Given this list of marker genes CCDC102B, BTNL8 (butyrophilin like 8), KMT5A, PGAP6, CDH8, CD320, SEZ6L2, SDHA, TUBGCP5, TPRA1, WWC2, SCN2B, TMEM259 (NCBI Gene Id 91304), BCAM, EHBP1L1, ATG4B, SMG1, MAP4K2, NAA15, ATP13A2, RING1, EGFL7, CAPG, KMT2D, TRPM4, SPTB, IKZF5, ADAM15, KDM2A, MAD1L1, ALKBH4, SGK1, GNA13, FBXO40, PHC2, TOLLIP, PYCR3, ZNF250, GRAPL-AS1, BCKDK (NCBI Gene Id 94996), NFKB2, SNX29P2, SLC52A2, ZNF688, DNAJB5, CAPN15, SMTN, ZWILCH, ZNF512B, HIC1, NAA35, FGF20, GCM2, LMAN1, GJC2, DBF4, PKN1, RAPGEF1, ZFP37, MBD3, IFT81, MSMB, LRRC23, SNCB, PITPNM1, PKP1, SH3GLB2, DMBT1, NECTIN3, TACR3, CDH9, NSMF, BAG6, NCOA3, COMT, ZNF652, EPHA1, POU3F4, ANKHD1, PSMC3IP, USP7, ST7L, THOP1, USF2, TEX12, GFUS, H2BC7, RER1, TUBB3, CAD, VEZF1, UNKL, DNAJC24, RAB23, PRRC1, PLK3, PDZRN3, FMNL1, DOK3, CDK16, RFNG, NACC2, GLP2R, ZKSCAN4 (zinc finger with KRAB and SCAN domains 4), SPRR1B (small proline rich protein 1B), SCAND1, ZNF574, FAM149B1, LHX2, BICDL1, APBB3, WEE1, ILKAP, CENPB, ASIP, ZNF148, ARPC2, RABL3, FRAT1, POLD1, GNB2, IER2, PTOV1, EMX1, CDKN2AIP, LMF2, HOXD11, ATP11A, PPP1R3C, GCC1, CDK7, TPM4, CRY2, ZBED1, RELB, KIR2DS1, DESI1, CIZ1, PLEC, UPF1, MISP (NCBI Gene Id 126353), ZBTB25, FRS3, CYP3A4, B4GALT2, CDX1, ZNF74, SRPRA, AURKAIP1, VPS4A, A4GNT, DNAAF2, OLIG2, FAAH (fatty acid amide hydrolase), GPC1, PRKCZ-AS1 (PRKCZ antisense RNA 1), RPS6KB2, TRPC4AP, MVD, FGF6, SNAI2, FAM89B, USP11, RECQL5 (NCBI Gene Id 9400), ZNF814, MEF2D, AHCY, CBX4, ACVRL1, LMAN2, IKZF2, NKTR, BBC3, MGAT1, SBF1 (NCBI Gene Id 6305), MAPK1, LINC02981, HOMER3, KRT7, LPAL2, CAPN10, TTC38 (tetratricopeptide repeat domain 38, NCBI Gene Id 55020), PFKL, MID1IP1, PLXNB2, TULP1, RGS9, DTX2, C1orf216, CXCR4, GINS4, ITPA, ID1, PPP5C, GASK1B, BRD4 (NCBI Gene Id 90616), here is a description of the gene set: Human Gene Set: GSE1432_CTRL_VS_IFNG_1H_MICROGLIA_UP from publication Rock RB, Hu S, Deshpande A, Munir S, May BJ, Baker CA, Peterson PK, Kapur V (PMID 16163375) Microglial cells are resident macrophages in the central nervous system (CNS) and play a pivotal role in the innate and adaptive immune responses against microbial infections. The immune functions of microglia are regulated by a milieu of cytokines including interferon (IFN)-gamma. We here performed a series of experiments to acertain the transcriptional profile of human fetal microglial cells at 1, 6, and 24 h after IFN-gamma treatment. Primary human microglial cells were either untreated or treated with 200u/ml IFN-gamma. Affymetrix U133A chips were utilized. Four different tissue samples (B18, O, W, and Y20) were analyzed at the three time points. Genes up-regulated in comparison of control microglia cells versus those 1 h after stimulation with IFNG. studied in species Homo sapiens